The following is a description of a gene set: Mouse Gene Set: GOMF_AXON_GUIDANCE_RECEPTOR_ACTIVITY species: Mus musculus Combining with an extracellular messenger and transmitting the signal from one side of the membrane to the other to results in a change in cellular activity involved in axon guidance., and this is the list of marker genes: Palld, Ephb1, L1cam, Ephb2, Gfra3, Hmcn2, Robo1, Sema5a, Ephb3 (NCBI Gene Id 13845), Epha7, Robo2